The following is a description of a gene set: ncRNAs involved in STAT3 signaling in hepatocellular carcinoma studied in species Homo sapiens Human Gene Set: WP_NCRNAS_INVOLVED_IN_STAT3_SIGNALING_IN_HEPATOCELLULAR_CARCINOMA, and this is the list of marker genes: SOX4, RELA, MIR21 (microRNA 21), IL6, JAK2, MIR200C, JAK3, IL6R, IL11, MIR200A, IL11RA, MIR200B, STAT3, NFKB1, JAK1, IL6ST, ZEB1